The following is a description of a gene set: The repair of double-strand breaks in DNA via homologous and nonhomologous mechanisms to reform a continuous DNA helix that contributes to reciprocal meiotic recombination. Human Gene Set: GOBP_DOUBLE_STRAND_BREAK_REPAIR_INVOLVED_IN_MEIOTIC_RECOMBINATION species: Homo sapiens, and this is the list of marker genes: BRIP1, PRDM9, MAJIN, BRME1, MCMDC2, HSF2BP, DMC1, FANCD2, SPO11, TERB2 (NCBI Gene Id 145645), TERB1, RAD51